Given this list of marker genes Abca5, Abcg1, Pnpla2 (NCBI Gene Id 68551), Osbpl8, Pparg, Apoa1, Prelid1, Cyp4a31, Galr1, Abca8a, Itgav, Myb, Gal, Abca8b, Lipg, C1qtnf1, Akt1, Lpl, Fabp3, Ces1b, Mup1, Cry2 (NCBI Gene Id 99248), Tnfsf11, Lep, Ehd1, Apoc3, Apoc1, Ttc39b, Ces1c, Lamtor1, Adipoq, Ppard, Irs2, Cyp2j5, Mfn2, Atp8a1, Ikbke, Apob, Abca2, Abca3, Mup11, Abca7, Eepd1, Nfkbia, Pla2g3, Atp8a2, Fxn, Spp1, Cyp19a1, Abca13, Map2k6, Sar1b, Kcnk9, Tspo, Mup2, Ptpn2, Ces1f, Avpr1b, Scp2, Hrh2, Cd36, Cyp4a10, Nmb, Abcg4, Edn1, Pla2r1, Lrp1, Retn, Clstn3, Tmem97 (NCBI Gene Id 69071), Mup4, Ces1h, Yjefn3, Pltp, Repin1, Crhr1, Ces1a, Tnfrsf11a, Ttc39d, Nr1h2, Tmf1, Ppara, Dbi, Mapk9, Agtr1a, Nkx3-1, Itgb3, Asxl2, Ecrg4, Ren1, Trem2, Shh, Abca12, Gdf9, Scarb1, Nrg1, Asxl1, Nus1, Igfbp3, Apoc2l, P2ry2, Ntsr1, Runx1 (runt related transcription factor 1), Prap1, Eprs1, Xrcc4, Hbp1, Irak1, Pla2g6, Abhd5, Cyp4a32, Pla2g4a, C3, Nr1h3, Fasl, Apoa2, Mup3, Washc1, Lpcat3, Dennd5b, Cav1, Arv1, Dab2 (disabled 2, mitogen-responsive phosphoprotein), Acacb, Cry1 (cryptochrome circadian regulator 1), Pomc (pro-opiomelanocortin-alpha), Abcb4, Ghrl, Kdm5b, Abca1, Apoc2, P2rx7, Surf4, Agtr2, Fis1, Ptch1, Erfe, Il1b, Gps2, Triap1, Apoe, Crh, Plin5, Pla2g10, Bmp6, Pon1, Oxt, Nucb2, Mup5, Thbs1, Acsl6, Furin, Lrat, Hilpda, Commd1, Anxa2, Ces1g, Zc3h12a, Osbpl11, Mif, Plin3, Hrh3, Srebf2, Sstr4, Akt2, Egf, Osbpl6, Plin2, Naxe, Vstm2a, Syk, Ldlrap1, Zdhhc8, Prkcd, Acsl1 (NCBI Gene Id 56355), Il1a, Sirt1, Tac1, Acsl4 (NCBI Gene Id 50790), Msr1, Ces1e, Ptpn11, Apoa4, Ptges, Tmem135, Tmem30a, Agt, Sec24a, Atp5pf, Pcsk9, Nfkb1, Apoc4 (NCBI Gene Id 11425), Acsl5, Crp, Ces1d, here is a description of the gene set: Mouse Gene Set: GOBP_REGULATION_OF_LIPID_LOCALIZATION Any process that modulates the frequency, rate or extent of lipid localization. species: Mus musculus